Given this list of marker genes SMDT1, NHERF1, ATP1B1, LRRC26, ACE2, PRKACA, ATP1B3, CLTRN, ABCC9, WNK3, ANK2, LRRC55, ATP1B2, LRRC38, PDZK1, ANK3, HFE, FHL1, RANGRF, SUMO1, ACTN2, ATP6AP1, AKT1, STK39, AKAP9, LRRC52, here is a description of the gene set: Human Gene Set: GOMF_TRANSPORTER_ACTIVATOR_ACTIVITY species: Homo sapiens Binds to and increases the activity of a transporter.